Given this list of marker genes ANXA4, PPIB, GDPD5, ANP32A, CD1D, TLX1, MGMT, CABP7, CISH, MGAT5B, PFKFB1 (6-phosphofructo-2-kinase/fructose-2,6-biphosphatase 1), CNTNAP1, C1orf198, SOX14, MBD1, ZCCHC18, CEP162, PRSS55, MRPS6, ASCC2, MSRB3, MTMR1, MDH1, PPP2R5D (protein phosphatase 2 regulatory subunit B'delta), ATP5MF, PRKAR1B, OTX1, ZNF281, ERMARD, EMC3, TEX10, MAGED1, GATAD1, ITIH5, MAGI1, ICAM1, CER1, RIN2, NCBP2 (nuclear cap binding protein subunit 2), HORMAD2, SRXN1, MYOC, PCK2 (NCBI Gene Id 5106), LHFPL5, SH2B2, NARS1, CNKSR3, SLC7A11, ITPKC, MID2, DDX18, FIBIN, NINJ1, NEB, ZBTB39, MROH9, INSR, CIMAP1B, PTPRB, EPHX4, ABCB1, ITPR2, IL10 (interleukin 10), NRTN, YAF2, GRB14, TNFRSF18 (NCBI Gene Id 8784), BCL2L1, EPCAM, DOCK3, DYSF (NCBI Gene Id 8291), MAP3K9, PCSK1, KLRG1, CYP8B1, CNPY2, SAAL1, ARHGAP22, STAT5B, GSN, IRX5, TEKT1, AOX1, CBX7, IL23A (interleukin 23 subunit alpha), DNAH7, MPHOSPH8, RASAL2, TSPAN7, FLRT3, IL5RA, CRTAP, INPP5F, PDE2A (phosphodiesterase 2A), SEPTIN7, L2HGDH, BAZ2B, NSMCE1, EPB41L2, HMGN3, TRPM4, SLC52A3, PRAMEF8, ENDOG, TMEM63C, RNF215, TIRAP, COL23A1, SLC37A2, SH3GL3, GNL2, FAH (NCBI Gene Id 2184), OR2C1, FBLN2, CYFIP1, CHD6, STON1, RAD51B, FNTA, TMEM86B, IFT27, MYB (MYB proto-oncogene, transcription factor), MPPED1, APOB, PIM1, IRF4, ZNF260, PHF10, PRCP, NUP133, PPM1N, TRIM2, RNF112, RCAN3, UBE2D2, ERBB3, ALMS1, SOD1 (NCBI Gene Id 6647), ZNF408, SLC23A1, H1-10, KLHL22, CNOT2, DZIP3 (NCBI Gene Id 9666), CLEC10A, NDUFB9, LRBA, GINS2, HTRA2, PGLYRP1, TEKT4, DCXR, AGK (NCBI Gene Id 55750), OTUD6B, TAGAP, TNFRSF4, CHRNB1, NQO1, PRL, A4GALT, MYEF2, KLHDC2, CLTRN (collectrin, amino acid transport regulator), COL15A1, ZFP42, C19orf18, ULK3, SNX9, IRAK2, RAPH1, GNPAT, FAM89A, TRIM29, TFDP1, NBL1, ADCY10, MYCN, ZFYVE19, GABPB1, PATJ, PEX16, RPGRIP1, USP54, CSPP1 (NCBI Gene Id 79848), HTR3B, NRP1, TNFAIP1, TMPRSS11E, STAT1, LAMTOR5, TJP3, KCNQ2 (potassium voltage-gated channel subfamily Q member 2), FAM81A, TRIM9, NME1, PTGS2, CMYA5, ZFP36L1, here is a description of the gene set: from publication Suryani S, Fulcher DA, Santner-Nanan B, Nanan R, Wong M, Shaw PJ, Gibson J, Williams A, Tangye SG (PMID 19965666) studied in species Homo sapiens Genes up-regulated in B lymphocytes: memory versus transitional CR2 high. Goals/objectives: to identify various gene expression in B cell subsets derived from human PBMC and cord blood Human Gene Set: GSE17186_MEMORY_VS_CD21HIGH_TRANSITIONAL_BCELL_UP